Given this list of marker genes POLRMT, CDC73, ALK, TNFSF11, ANKH, ENPP1, SLC34A3, CASR (calcium sensing receptor), OCRL, BRAF, KRAS, HMGCS2, SLC34A1, NAB2 (NGFI-A binding protein 2), SNX10, NRAS, GCM2, HRAS, FAM111A, NDUFAF6, COL4A3, CYP27B1, EHHADH, KCNJ18, MEN1, GATM, FAM20C, CLCN5, PTH1R, NHERF1, CYP3A4, TCIRG1, SOX5, CYP2R1, STAT6, CTNS, DMP1, AP2S1, CLCN7, ABCC6, INPPL1, SLC2A2, HNF4A, FAH, ALDOB, FGF23, VDR, CACNA1S, GNAS, ZEB2, GABRA3, PHEX, RAF1, here is a description of the gene set: Hypophosphatemia studied in species Homo sapiens An abnormally decreased phosphate concentration in the blood. Human Gene Set: HP_HYPOPHOSPHATEMIA